The following is a description of a gene set: studied in species Homo sapiens The chemical reactions and pathways resulting in the formation of phosphatidylcholines, any of a class of glycerophospholipids in which the phosphatidyl group is esterified to the hydroxyl group of choline. Human Gene Set: GOBP_PHOSPHATIDYLCHOLINE_BIOSYNTHETIC_PROCESS, and this is the list of marker genes: PCYT1A, CAPN2, FABP3, SLC44A1, SLC44A4, FABP5, LPCAT1, LCAT, LPCAT3, MFSD2A, CEPT1, ACSL3, PEMT (phosphatidylethanolamine N-methyltransferase), CHPT1, CHKA, APOA2, SLC44A5, ABHD3, SLC44A2, RAB38, CHKB, APOA1, CDS1, CHAT, SLC44A3, PCYT1B (NCBI Gene Id 9468), GPAT4